The following is a description of a gene set: part of: Membrane Trafficking electronically inferred by orthology from the curated human pathway Reactome Pathway: Endosomal Sorting Complex Required For Transport (ESCRT) This event has been computationally inferred from an event that has been demonstrated in another species.<p>The inference is based on the homology mapping from PANTHER. Briefly, reactions for which all involved PhysicalEntities (in input, output and catalyst) have a mapped orthologue/paralogue (for complexes at least 75% of components must have a mapping) are inferred to the other species. species: Mus musculus, and this is the list of marker genes: Chmp2a, Vps37d, Vps37c, Chmp5, Snf8, Mvb12a, Ubap1, Chmp2b, Ubb, Stam, Tsg101, Rps27a